Given this list of marker genes SIRPB1, USP2, CREB1, LARP4B, CUL2, KRT6A, SCN8A, THEM5, FAM131B, FA2H, FOXP4, TMEM100, RIMS4, ING4, EIF4G3, FUBP3 (NCBI Gene Id 8939), KRT6C, LINC02914, MXI1, STAT3, MBD6, MOB3C, CEP85, CHD6, CNTD1, SOCS3, NONO, PDE1B, FHIP1A (FHF complex subunit HOOK interacting protein 1A), BCAT1, KDM2A, SDC3, FCHSD2, PTPN7, NCS1, KIF1A, NHEJ1, POU2F2, PIK3C2B, RNF144B, EDIL3, DZIP3, EEIG1, TBCEL, KRT74, DCUN1D1, CBX6, KRTAP4-12, EXOSC5, SPAG17, MMP15, TRAF4, CA13, AGPAT4, SUMF2, DIPK2B, PALM2AKAP2, SCN1B, STRADB, MOB3A, PAPOLG, ATP6V1A, LRRC59, PRR3, NCOA1, PPP2R1B (NCBI Gene Id 5519), GCLM, ATXN1, EXOG, MFHAS1, VCAN, KLF6, CHST2, SHC1, HTR6, INO80D, MUL1, RAB2B, ALX4, U2SURP, DHX15, NTRK2 (NCBI Gene Id 4915), RGS7, MITF, TGM4, ARHGDIA, SLC25A35 (NCBI Gene Id 399512), GIN1, RNF4, NR6A1, ADCK1, CAPN5, INKA2, PRDM9, C7, ELL, NFASC, TSPAN6, HYAL4, CACNA2D4, SYDE1, F2RL2, PIP5K1A, SLC36A1, LMBRD1, LRP6, HTR3E, PDS5A, WASF2, GALK1, PPP1R9B, LDLRAP1, BCAS4, MTA2, EBF3, TTBK1, PTPRJ, IFT80, here is a description of the gene set: Human Gene Set: MIR3612 from publication Chen Y, Wang X (PMID 31504780) studied in species Homo sapiens Genes predicted to be targets of miRBase v22 microRNA hsa-miR-3612 in miRDB v6.0 with MirTarget v4 prediction scores > 80 (high confidence targets).